The following is a description of a gene set: from publication Fan X, Bialecka M, Moustakas I, Lam E, Torrens-Juaneda V, Borggreven NV, Trouw L, Louwe LA, Pilgram GSK, Mei H, van der Westerlaken L, Chuva de Sousa Lopes SM (PMID 31320652) Pseudotime analysis using Monocle 3 alpha, that places the progenitor cell population in the middle of a longer trajectory segment, revealed that pGC (CL15) branched to mural GC (CL11) and mature cumulus GC (CL8 and CL3) (Fig. 6a). Human Gene Set: FAN_OVARY_CL8_MATURE_CUMULUS_GRANULOSA_CELL_2 species: Homo sapiens, and this is the list of marker genes: CCDC167 (NCBI Gene Id 353272), GJA1, CLIC1, GSTA4, STMN3, PEG3, PPP1R12B, VDAC3, NIPSNAP2, TCEAL2, CLNS1A, UBE2C, NDUFB3, ENTPD6, MRPL16, PGLS, MICOS10, HSBP1, UBE2E2, SRI, KTN1, RPL26L1, POLR2F, C1QBP, FIBP, SOWAHC, TCEA3, MGARP, NHP2, JPT1, MT-ATP6, ATP1B1, IFI35, PPP1R14A, RALB, BEX5, LPL, RPL35 (NCBI Gene Id 92393), CHGB, FMC1, PRKAR2B, DNAJC19, OSGIN2 (NCBI Gene Id 734), COX5B, RNF7, MRPL33, ANP32B, MRPL23, AURKAIP1, COPZ1, NEDD8, RBIS, EIF1AD (eukaryotic translation initiation factor 1A domain containing), GREB1, SELENOH, CALM2, SNRPD2, ABRACL, DECR1, CYP20A1, NDUFS4, COPS9, TANC2, ZNF358, CCDC124, TSPAN7, PSMA4, NSG1, FDXR, MRPL14, CDH3, MRPL24, PSMD4, LPIN2, MRPL11, PGM1, PYURF, TMEM134, PPDPF, TNNI3, NDUFS7, BTF3L4, HSPG2, PARK7, MARCKS, CFDP1, MZT2B, SUMO3, MRPL51, NDUFB7, ERH, COX6B1, MYL6, DAPL1, TRAPPC1, CBX5, FAM78A, MAGED2, STOML2, NDFIP1, NDP, POR, ENAH, SNRPE, OST4, SDHC, PSMB5 (NCBI Gene Id 5693), EPDR1, COX7A2, LAMTOR2, MDH2, BCAT1, TMEM120A, RPL27A, DUSP23, CD320, GTF2H5, DNPH1, FHL2, TXNDC17, MIR202HG, PTRHD1, CCDC69, LSM7, NDUFS6 (NCBI Gene Id 4726), VPS8, DDOST (dolichyl-diphosphooligosaccharide--protein glycosyltransferase non-catalytic subunit), RBBP4, DSP, PDIA4, AMH, KNOP1, ECHDC3, PLP1, IRF4, NDUFA13, ANP32A, GATM, CSGALNACT1, LDHB, PSME3IP1, ST3GAL4, IFI6, TIMM17B, ADCK2, ERCC1, P3H2, GADD45GIP1, MRPS15, BAX, NREP (NCBI Gene Id 9315), SERF2, CMTM3, SMIM1, TMEM123, WDR18, RPS29, HEY2, HS2ST1, PRMT2, NUP214, ACTB (NCBI Gene Id 60), MSRB2, PFN1, RNASE1, VDAC1, LLPH (NCBI Gene Id 84298), HMGB3, MT-CYB, MARCKSL1, RPL37A, PLIN3, SMAD3, PYCARD, SNAPIN, RPL39, TCEAL8, MRPL22, SPINT2, MRPS14, RPA3, MGST3, PEMT, TMEM14B, VPS35, HNRNPA1L2, DPY30, SUSD3, AVPI1, BAMBI, SEC31A, PRDX5, CMTM6, HS6ST1, MT1X, IDH1, S100A10, H1-10, CFI, UBL5, DAG1, SMIM30, ATP5ME, SEPTIN10, MRPL4, ROMO1, NAV2, EIF4EBP1, NDUFC1, MYO10, TMEM106C, UQCC2, PPIB, PLAAT3, MAGED1, ETFA, COMMD1, SSBP1, ALDH18A1, SLC16A1, SMAD4, MFAP2, LAGE3, VEGFA, MIF, CRHBP, MRPL57, UROS, FUNDC1, SMARCB1, HTRA1, FBXW5, SRSF9, COL4A2, MRPS21, PRR15, DYNLT1, ECHS1, TMED9, YIF1B, TBCA (tubulin folding cofactor A), RNF19A, DTNBP1, PPIF, PRDX2, COL4A1, TMEM258, ALDOA, ATP5MC3, VAT1, ARHGEF6, MGST2, NDUFB10, TRAPPC2L, PDHB, ARL2, CMTM8, EMX2, LIMS2, HMGB2, DAD1, SNRNP25, PET100, CETN3, GSTA1, SNRPD3, TRMT112, SLC25A6, NICOL1, UQCRQ, MKRN1, FOXL2, LSM6, ARL2BP, HDDC2, NR5A2, MPC2, CRNDE, HSDL2, CENATAC, RCN2, CASP6, RPS28, TMED10, NDUFS5, DYNLRB1, SSBP3, ATP5MK, MPST, HMGB1, OLA1, RPL17, PLA2G12A, DST, HIF1A (hypoxia inducible factor 1 subunit alpha), ATP5F1E, TCEAL9, ERI3, TMSB10, NDUFB11, TSPAN6, TPRKB, PARP1, DGUOK, TUBB, NDUFB1, FSCN1, SLIRP, PRSS23, C7orf50, HPF1, RIN2, ATP5MC1, PRKDC, NDUFS8, PSMA3, HDHD3, MACROH2A1, IVNS1ABP, NDUFB6, ATP5PF, SLC25A5, LCMT1, NDUFAF3, C19orf48P, STMP1, SPIN1, ATP5F1B, POLD2, MRPL41, CHL1, IHH, NAXE, NDUFC2 (NCBI Gene Id 4718), CALM3, RPS21, ITGB1, EEF1G, INHBB, TBCB, PCNA, SERPINE2, APRT, MAP4K4, MSI2, APOBEC3C, TMEM14A, MT-ND5, CHID1, LMBR1L, GRIK1, PHB1, COMT, MACROH2A2, NDUFA2, REEP6, INHA, DPYSL3, IFI27, CCDC90B, RNASEH2C, LSM2, MT-ND3, CCND2, TP53I3, ATP5MF, SNRPN, PXMP2, UBE2V2, PHF6, ATP5MG, ECH1, STMN1, MAP3K13, TXN2, EPB41L2 (erythrocyte membrane protein band 4.1 like 2), ARF5, PABPN1, MICOS13, ACADM, NDUFB9, ARPC3, MRPS33, TMA7, CD99, ELK1, ATP5MJ, ARF3 (NCBI Gene Id 377), PDIA6, HIGD2A, NME1, TMEM97, MT-ND4, MRPL3, COX5A, NDUFB2, ATP5F1A, SPRR2F, ATP5IF1 (NCBI Gene Id 93974), CARHSP1, POLR2L, MSH6, PPP1R13L, COX6A1, POLDIP2, FST (NCBI Gene Id 10468), FDFT1, GTF2I, CKS1B, ACSL4, GAS6, POLR3GL (NCBI Gene Id 84265), USO1, CKB, CD47, BHLHE40, ATRAID, TRAPPC4, UBXN8, NBEAL1, AP1S1, NDUFB5, MT-CO2, MPHOSPH6, ACTL6A, FEZ2, DMAC1, NDUFA1 (NADH:ubiquinone oxidoreductase subunit A1), NDUFB4, SET, ARPC5, SMS, PGD, ARPC2, UQCR11, SEMA7A, SNRPD1, METTL26, PAM, VPS29, NDUFB8 (NCBI Gene Id 4714), SIGLEC11, PNKD, IGFBP2, TIMM13, HDAC2, TSHZ2, PRXL2A, TMEM176B, EPHX1, HSD17B10, DUT, SEC61G, ATP5MC2, SLC39A8, TRAPPC6A, UQCR10, CHCHD5, BANF1, COPE, TMSB4X, MDK, CHCHD10, PPHLN1 (NCBI Gene Id 51535), GNG5, HINT1, TCAF1, OSTC, MRPS34, POLR2G, BMPR2, CDH2, PSMB6, PLEKHJ1, PDGFC, NUCKS1, PSMB3, LSM3, HMGN1, HOPX, H1-0, HIKESHI, S100A16, H3-3A, BEX4, ELOB, MRPL55, APOA1, MEX3C, UQCRH, CKS2, LY6E, HINT2, COX8A, NME4, SEC14L1, CHCHD6, PHPT1, MZT2A, HNRNPA1, CUEDC2 (NCBI Gene Id 79004), GRB14, MRPS26, NIT2, MEX3B, SRP9, PYCR2, NDUFAF8, THOC7, IFI27L1, FKBP3, WIPF3 (WAS/WASL interacting protein family member 3), POMP, PTS, RBX1, HSD17B1, LSM4, IQGAP1, NDUFA7, PHEX, PIN1, FDPS, CIAO2B, MT1F, GTF3C6, NDUFA3, SNRPC, PON2, KRT8, NAA38, SYNE2, TUBA1B, NDUFA11, DPM3, HMGN2, MYL6B, TSTD1, DGCR6L (DiGeorge syndrome critical region gene 6 like), HS3ST1, MT-CO1, GSTP1, EIF4G1, ME2, UQCRFS1, GREM1, COX7C, ERG28, SNX18, UQCRC1, TXNDC12, S100B, PRDX3, CBX3, TLE5, SQLE, ACAA2, ST6GAL2, ATP5F1C, CAMTA1, EAPP, HUWE1, H4C3, ATOX1, BEX1, ATXN10, NME2, THYN1, COX17, COA3, SCD (NCBI Gene Id 6319), GSS (NCBI Gene Id 2937), XPO1, LAPTM4A, DONSON, RPS25, NDUFA12, AKR1B1, PCBP2, DYNLL1, ZNHIT1, COX16, ANAPC11, SNF8, YAP1, CTSV, NUTF2, PRRT1, VCAN, NDUFAB1, LSM5, MDH1, EEF1E1, MT-ND4L, GSDMD, CKAP2, SUMO2, FKBP9, COMMD4, PRDX4, BEX3 (NCBI Gene Id 27018), MRPL12, MYO1B, QDPR, AP2S1, LGALS3BP, FRMD4B, MT-CO3, PPARG, ACIN1, TM7SF2, MRPL52, CNPY3, ACAT2, RANBP1, TUBA1A, LMAN2, TMEM147, TIMM8B, ANXA6, RBP1, USP48, PAFAH1B3, POLR2I (NCBI Gene Id 5438, RNA polymerase II subunit I), BLOC1S1, PPP1CA, LRAT, SEM1, RPS27L, DBI, SRPX, GATA4, RIMS4, NDUFA4, SFRP4, HNRNPD, SNRPF, RHOB, OCIAD2, CTNNB1, PFDN4, PIN4, ATP5PO, HIGD1A, LAPTM4B, ZNF428, TMEM141